Given this list of marker genes CYP19A1, OXT (oxytocin/neurophysin I prepropeptide), P2RX7, FZD4, KDM5B, CRY1, SPP1, GDF9, NMB, NKX3-1, AGT, DAB2, IL1B (interleukin 1 beta), SAR1B, KCNQ1, GHRL, TMF1, BMP6, P2RX4, EDN1 (endothelin 1), PLA2G4A, ACSL4, KCNK9, POMC, TNFRSF11A, TNFSF11, INHBA, ABCC4, LEP, GAL, CRY2, CRHR1, PLA2G3, C1QTNF1, PTGS2, NOS2, MYB, SELENOM (selenoprotein M), TSPO, RETN, AGTR1, PTGES, CRH (corticotropin releasing hormone), GALR1, PTPN11, SURF4 (NCBI Gene Id 6836), TAC1, PLA2G10, MIF, WNK4, ECRG4, REN, here is a description of the gene set: Human Gene Set: GOBP_LIPID_EXPORT_FROM_CELL The directed movement of a lipid from a cell, into the extracellular region. species: Homo sapiens